Given this list of marker genes Pck1, Tsc1, Bcl6, Fgl2, Cd46, Itgb6, H2-Ea (histocompatibility 2, class II antigen E alpha), Itgb8, St3gal1, Il23a, Tnfsf4, here is a description of the gene set: Mouse Gene Set: GOBP_IMMUNOLOGICAL_MEMORY_FORMATION_PROCESS Any immunological memory process that can contribute to the formation of immunological memory. species: Mus musculus